Given this list of marker genes HOOK1, DEFB103B, RBM25, PMAIP1, SLC6A20, LY6K, NPTX1, LIN9, TMEM106B, TATDN2, DCUN1D3, BLCAP, SEMA6D, DPP8, RIPK1, TMEM43, ANK3, GSR, CCNG1, NSDHL, MPZL2, UBL3, KLF6, CCDC88A, DAPK2 (death associated protein kinase 2), NAA80, GBA1, TMEM47, CHI3L1, PMEPA1, USF3, SEMA4D, HMOX1, KIF1B, UTRN, FBLIM1, PDPN, COBLL1, ZHX2, HBA2 (NCBI Gene Id 3040), GSK3B, BTBD10, GPAT3, PDE6B, UGCG, CASTOR2, LXN, CREBBP, ODC1, ESM1, GPR137B, PTPN12, TNPO1, PLPP6, CCDC65, LAMA3, CCNY, SLC4A7, SCHIP1, MYH9, CAT, RIPK4, ITGA6, FAM168B, FARSB, CSRNP1, RFNG, PFN1, APLN, CAMK2D, SPRED3, HDAC6, CRYBG3, ASAP1, YOD1, CPEB4, UBASH3B, TAOK1, DHX37, PTPRZ1, YWHAZ, N4BP1, GSTA1, KLK10, PLK2, DEFB1, FHOD1, DIP2B, MAP3K20, ITGB1, LGALS3BP, GALNT12, ABCG1, AKR1D1, DLG1, FCHSD2, MAPK6, ZNF131 (NCBI Gene Id 7690), ARAP2, PLD1, MYO5B, CPNE2, RAP1GAP, B4GALT1, PNCK, NRIP1, PHLDB2, FMN1, PTGS2, ACOX1, SLPI, CDC40 (cell division cycle 40), NPLOC4, DDX6, DEDD, OGA, AHCYL2, SMAD7, AFF4, ESD, SAMHD1, LETMD1, ENAH, HAPSTR1, RAB22A, RALB, TMEM163, TPBG, PEAK1, KIF5B, TMX3, AQP3 (NCBI Gene Id 360), RAPGEF3, RANBP9, ADNP, SMURF1, SNN, RAB11FIP1, FLRT3, CLIP4, ATP13A3, MAFK, ADD2, KRT13, KLK12, NFE2L2, TPM1, FETUB, HS3ST1, HMGCS1, SERPINB6, RNF38, HMMR, MED13, DDX49, MYH6, RBP1, LARP4B, SHROOM3, PXK, DEFB4A (NCBI Gene Id 1673), ATP2C1, PTBP3, EEA1, SEMA3C, GM2A, MXD1, NET1, SQLE, HOMER3, LTN1, ZDHHC5, TPP1, CD80, FABP4, ARID3A, FOS, QKI, EPS8, LRRC57, OR2B2, IRS2, KDM5B (NCBI Gene Id 10765), UBL4A, CD44, XDH, ZNF436, ATF7IP, CADM1, GJB6, MAGED2, PIP5K1B, DEGS2, SMG1, AGPS, ALDH1A3, MACF1, CLIP1, MAP4K4, DAP, FAM83G, RUNX1, ARNT, PRP4K, LRP8, SNX9, MMP10, MBOAT1 (membrane bound O-acyltransferase domain containing 1), HPGDS, PIK3CB, MAU2, CAMSAP2, BCAR3, MET, NRG1, PHLDA1, CEP350, HBD, KCNN4, PAK1, CAST, TWF1, ADARB1, TPM4, RBBP4, ADAM12, STX11 (NCBI Gene Id 8676), MMP3, UBAP1, FLRT2, TBL1X, NVL, LYG1, CTNND1, WDFY2, UBE2Q2, ELL2, HOXA1, CMTM4, COMMD10, TPD52, APLP2, RUSC2, STK3, STIM2, DOCK1, ENTR1, GIT2, CRABP2, PRCC, KLF3, HIPK3, IL36G, DSG3, GKN1, TIPARP, KIAA0513, UCK2, DDX3X (DEAD-box helicase 3 X-linked), ABCC1, VGLL3, TGFBI, TMEM248, PIAS1, EAF1, here is a description of the gene set: Expression and function of the oncogenic transcription factor activator protein (AP-1; mainly composed of Jun and Fos proteins) is required for neoplastic transformation of keratinocytes in vitro and tumor promotion as well as malignant progression in vivo. Here, we describe the identification of 372 differentially expressed genes comparing skin tumor samples of K5-SOS-F transgenic mice (Fos(f/f) SOS(+)) with samples derived from animals with a specific deletion of c-Fos in keratinocytes (Fos(Deltaep) SOS(+)). Fos-dependent transcription of selected genes was confirmed by quantitative real-time PCR analysis using tumor samples and mouse back skin treated with the tumor promoter 12-O-tetradecanoylphorbol-13-acetate (TPA). One of the most differentially expressed genes encodes the small mucin-like glycoprotein Podoplanin (Pdpn), whose expression correlates with malignant progression in mouse tumor model systems and human cancer. We found Pdpn and Fos expression in chemically induced mouse skin tumors, and detailed analysis of the Pdpn gene promoter revealed impaired activity in Fos-deficient mouse embryonic fibroblasts, which could be restored by ectopic Fos expression. Direct Fos protein binding to the Pdpn promoter was shown by chromatin immunoprecipitation and a TPA-induced complex at a TPA-responsive element-like motif in the proximal promoter was identified by electrophoretic mobility shift assays. In summary, we could define a Fos-dependent genetic program in a well-established model of skin tumors. Systematic analysis of these novel target genes will guide us in elucidating the molecular mechanisms of AP-1-regulated pathways that are critically implicated in neoplastic transformation and/or malignant progression. from publication Durchdewald M, Guinea-Viniegra J, Haag D, Riehl A, Lichter P, Hahn M, Wagner EF, Angel P, Hess J (PMID 18757399) Human Gene Set: DURCHDEWALD_SKIN_CARCINOGENESIS_DN Genes down-regulated upon skin specific knockout of FOS by cre-lox in the K5-SOS-F mice (express a constitutively active form of SOS1 in the skin). studied in species Mus musculus